The following is a description of a gene set: The gene expression program underlying the specification of human cell types is of fundamental interest. The study authors generated human cell atlases of gene expression and chromatin accessibility in fetal tissues. For gene expression, the study authors applied three-level combinatorial indexing to >110 samples representing 15 organs, ultimately profiling ~4 million single cells. The study authors leveraged the literature and other atlases to identify and annotate hundreds of cell types and subtypes, both within and across tissues. Our analyses focused on organ-specific specializations of broadly distributed cell types (such as blood, endothelial, and epithelial), sites of fetal erythropoiesis (which notably included the adrenal gland), and integration with mouse developmental atlases (such as conserved specification of blood cells). These data represent a rich resource for the exploration of in vivo human gene expression in diverse tissues and cell types. Marker genes curated from the annotated cluster as represented in the Descartes Human Gene Expression During Development database. from publication Cao J, O'Day DR, Pliner HA, Kingsley PD, Deng M, Daza RM, Zager MA, Aldinger KA, Blecher-Gonen R, Zhang F, Spielmann M, Palis J, Doherty D, Steemers FJ, Glass IA, Trapnell C, Shendure J (PMID 33184181) studied in species Homo sapiens Human Gene Set: DESCARTES_FETAL_ADRENAL_CSH1_CSH2_POSITIVE_CELLS, and this is the list of marker genes: IMPA1P1, PKIB, DEPP1, MUC15, SPINT1, SERPINB2, TMC1, PROSER2-AS1, MIR4280HG, PSG3, DNAI2, LINC02307, PGF, RCC2-AS1, PAPPA, PERP, YIPF2, TNS4, INHBA, PCDH11X, MAGI1-AS1, APPBP2-DT, ITGB4, CNKSR1, XAGE3, SERPINE1, HILPDA-AS1, RPL21P57, LINC01524, CSH1, GTF2I-AS1, ADRB1, RGPD2, ATF3, GPX3, ESRP1 (epithelial splicing regulatory protein 1), LINC01687, KRT7, NFE2L3, ENSG00000251095, PSG6, GDF15, PSG11, VGLL1, SVEP1, NOCT, BZW2, PSG1, GNGT1, LINC01418, GRHL1, TAS2R13 (taste 2 receptor member 13), STEAP4, ARHGEF5, TACC2, ENSG00000257283, SMIM2-AS1, PSG5, MORC4, PSG7, TFPI2, CHODL (chondrolectin), RASA1, ACKR2, SLC19A3, TGM2, USP43, SP6, LINC01194, LVRN, LINC00663, LINC02112, FAM83G, ITGB6, NFE4, LINC02055, FOXO6, L1TD1, PAPPA2, DACT2, CLDN4, TPRXL, LINC00578, XKRX (NCBI Gene Id 402415), ERRFI1, ENSG00000261632, GOLT1A, EXPH5 (NCBI Gene Id 23086), CPS1, MIR4713HG, LINC02327, SLC6A4, ENSG00000243273, ADAM12, SLC47A2 (solute carrier family 47 member 2), TCL6, MYL5, HSD17B1, RPL12P20, ERVFRD-1, SPTLC3, HCAR1, RPS12P26, MFSD2A, EPIC1 (epigenetically induced MYC interacting lncRNA 1), LINC00470, SPIRE2, CBR3-AS1, CGB3, ERVW-1, STEEP1, KRT23, AP1M2 (adaptor related protein complex 1 subunit mu 2), SCAND3, GYG2P1, KRT8, PRKCZ, MMP11, F5, EFEMP1, SLC22A11, PSG8, CAP2, SCIN, INSL4, LINC00964, OLR1, ANXA3, ASS1, CGA, HSD3B1, PRB1, KMO, RDH13, MIR4307HG, CAPN6, MET, ERVH48-1, PSG4, ENSG00000251574, LCMT1-AS2, RNU1-134P, ANGPT2, MAFF, C4orf36, S100P, PSG2, TMC5, FAM3B, TNFRSF12A, HOPX, FAM184A, KISS1, SMIM18, LINC02583, NLRP2, ATP6V1C2, SERINC2, ZNF93, TFAP2C, SDC1, NECTIN4, MCOLN3, NCMAP, TMEM184A, LINC01920, CSRP2, HSPB8, SLC13A4, ISM2, PPP1R13L, DUSP9, KRT18 (keratin 18), GH2, ST8SIA6-AS1, ENSG00000263745, PSG9, RNU6-272P, ZNF702P, CCDC54-AS1, GSTA3, PHLDA2, ZFAT, LYPD5, DYNLRB2 (NCBI Gene Id 83657), CLIC5, TRAPPC14, LINC00882, MAP3K2-DT, EPS8L1, DDX10P1, TP63, ENSG00000234352, ENSG00000250954, ENSG00000254951, KANK4, STS, SLC52A1, ALDH4A1, C1orf115, CPZ, LINC02540, HSD11B2, ANXA1, PAGE4, LRP2, TRIM29, GRIP1, NDOR1, PWWP3B, GRHL2, GPC1-AS1, ENSG00000227885, EFHD1, CYP19A1, CSH2, HTRA4, RASSF6, RIMKLB, LINC02899, PAPPA-AS1, LMO7-AS1, CLDN7, TM4SF19, LINC02616